The following is a description of a gene set: Ring scotoma An annular field defect centered on fixation. Human Gene Set: HP_RING_SCOTOMA species: Homo sapiens, and this is the list of marker genes: RLBP1, HGSNAT, FLVCR1 (FLVCR choline and heme transporter 1), TRNT1, ARSG, RPGR, RP2